Given this list of marker genes GPR161, CSNK1G3, PTCH1, HHIP, GLI2, SMO, KIF3A, EVC2, SMURF1, PTCH2, KIF7, PRKACG, DHH (desert hedgehog signaling molecule), SUFU, CSNK1A1, CSNK1A1L, BCL2, CCND2, CSNK1G1, LRP2, SMURF2, PRKACB, FBXL17, BOC, GAS1, SPOP, EVC, SPOPL, CUL3, SHH, GLI1, CSNK1D, CSNK1G2, IHH, GLI3, PRKACA, CSNK1E, CCND1, GRK3, CDON, ARRB1, GRK2, ARRB2, here is a description of the gene set: Hedgehog signaling studied in species Homo sapiens Human Gene Set: WP_HEDGEHOG_SIGNALING_WP4249